The following is a description of a gene set: Cardiac progenitor differentiation species: Homo sapiens Human Gene Set: WP_CARDIAC_PROGENITOR_DIFFERENTIATION, and this is the list of marker genes: SOX1, IGF2, NKX2-5, MESP2, NODAL, FGF2, TBX20, POU5F1, KIT, LIN28B, INS, ACTC1, SOX17, IGF1, SIRPA, THY1, ROR2, FOXA2, PDGFRA, MIXL1 (Mix paired-like homeobox), ZFP42, NOG, NANOG, DKK1 (dickkopf WNT signaling pathway inhibitor 1), ANPEP, BMP1, NOTCH1, IRX4, SOX2, ISL1, TBXT, PAX6, NCAM1, TBX5, MYL2, MAPK14, MYH6, GSK3B, TNNI3, SCN5A, NRG1, TGFB1, INHBA, TNNT2, MEF2C, WNT3A, KDR, MYLK3, LIN28A, MESP1, GATA4, BMP4, CXCR4